The following is a description of a gene set: The chemical reactions and pathways resulting in the breakdown of a nucleobase, a nitrogenous base that is a constituent of a nucleic acid. studied in species Mus musculus Mouse Gene Set: GOBP_NUCLEOBASE_CATABOLIC_PROCESS, and this is the list of marker genes: Crmp1, Dpysl5, Gda, Dpysl2, Dpyd, Urah, Uox, Aldh6a1 (NCBI Gene Id 67827), Dpys, Dpysl4, Xdh, Dpysl3, Urad